The following is a description of a gene set: Mouse Gene Set: GOBP_NEUROTRANSMITTER_UPTAKE studied in species Mus musculus The directed movement of neurotransmitters into neurons or glial cells. This process leads to inactivation and recycling of neurotransmitters., and this is the list of marker genes: Nat8l, Gdnf, Slc17a7, Slc29a1, Slc22a2, Slc6a9, Slc6a2, Fev, Slc6a11, Slc6a5, Itgb3, Slc29a4, Slc17a6, Park7, Gfap, Prkn, Itgb1, Slc1a2, Slc22a1, Slc29a2, Slc1a6, Cln8, Atp1a2, Slc6a4, Rab3b, Arl6ip5, Slc18b1, Per2, Slc22a3, Slc17a8, Slc6a3, App, Slc6a1, Syngr3, Slc18a1, Drd2, Snca, Flot1, Slc18a3, Slc18a2, Tor1a, Kcnj10, Gpm6b, Slc1a7, Nos1, Drd3